The following is a description of a gene set: electronically inferred by orthology from the curated human pathway studied in species Mus musculus This event has been computationally inferred from an event that has been demonstrated in another species.<p>The inference is based on the homology mapping from PANTHER. Briefly, reactions for which all involved PhysicalEntities (in input, output and catalyst) have a mapped orthologue/paralogue (for complexes at least 75% of components must have a mapping) are inferred to the other species. Reactome Pathway: NADPH regeneration part of: Metabolism of cofactors, and this is the list of marker genes: Aco1